The following is a description of a gene set: Genes having at least one occurrence of the highly conserved motif M172 TTGCWCAAY in the regions spanning 4 kb centered on their transcription starting sites. This matches the CEBPB transcription factor binding site V$CEBPB_02 (v7.4 TRANSFAC). Human Gene Set: TTGCWCAAY_CEBPB_02 studied in species Homo sapiens Comprehensive identification of all functional elements encoded in the human genome is a fundamental need in biomedical research. Here, we present a comparative analysis of the human, mouse, rat and dog genomes to create a systematic catalogue of common regulatory motifs in promoters and 3' untranslated regions (3' UTRs). The promoter analysis yields 174 candidate motifs, including most previously known transcription-factor binding sites and 105 new motifs. The 3'-UTR analysis yields 106 motifs likely to be involved in post-transcriptional regulation. Nearly one-half are associated with microRNAs (miRNAs), leading to the discovery of many new miRNA genes and their likely target genes. Our results suggest that previous estimates of the number of human miRNA genes were low, and that miRNAs regulate at least 20% of human genes. The overall results provide a systematic view of gene regulation in the human, which will be refined as additional mammalian genomes become available. from publication Xie X, Lu J, Kulbokas EJ, Golub TR, Mootha V, Lindblad-Toh K, Lander ES, Kellis M (PMID 15735639), and this is the list of marker genes: BNC2, NRP2, TRIB1, CSDE1, IP6K2, PRDX3, KRT23, PITX2, B4GALT1, JADE3, SOX10, KLF5, SYNCRIP, MIDEAS, CYP24A1, CEBPB, SPIB, MSH5, RAB2A, ACAN, DENND2D, SLC7A11, STMN1, WNT5A, SLIT3, VCAN, ITPR3, PPP1R3D, IL19, NFKBIE, SERPINE1, CUEDC1, DCAF6, KCNJ2, LUZP1, HOXA5, TMEM104, ZFP36L1, CKAP4, TOB1, MAPK14, EIF4A2 (eukaryotic translation initiation factor 4A2), DBH, NAT9, ETV6, BMF, SIK3, SRPK1, EIF4A1, PPL, TXLNG, GSR, CLDN10, FGA, RHOB, FAM217B, SAA1, FGF14 (NCBI Gene Id 317685), IDH1, SBSN, ZNF217, ANGPT1 (angiopoietin 1), CITED4